The following is a description of a gene set: Reactome Pathway: Glycogen breakdown (glycogenolysis) species: Homo sapiens Cytosolic glycogen breakdown occurs via the same chemical steps in all tissues but is separately regulated via tissue specific isozymes and signaling pathways that enable distinct physiological fates for liver glycogen and that in other tissues. Glycogen phosphorylase, which can be activated by phosphorylase kinase, catalyzes the removal of glucose residues as glucose 1-phosphate from the ends of glycogen branches. The final four residues of each branch are removed in two steps catalyzed by debranching enzyme, and further glycogen phosphorylase activity completes the process of glycogen breakdown. The figure shows the actions of phosphorylase and debranching enzyme. The first glucose residue in each branch is released as free glucose; all other residues are released as glucose 1-phosphate. The latter molecule can be converted to glucose 6-phosphate in a step shared with other pathways.<p>Glycogen can also be taken up into lysosomes, where it is normally broken done by the action of a single enzyme, lysosomal alpha-glucosidase (GAA).<p>Enzymes in liver generate 1,5-anhydro-D-fructose from glycogen, which in turn can be reduced to 1,5-anhydro-D-glucitol, a sequence of events that may represent a novel minor pathway for glycogen breakdown. part of: Glycogen metabolism, and this is the list of marker genes: AGL, PYGB, PHKB, PYGL, PYGM, GYG1, CALM1, PHKG1, GAA, PHKA1, AKR1E2, PGM1, PHKA2, PHKG2 (NCBI Gene Id 5261), GYG2